Given this list of marker genes Osr1, Dvl2, Irx1, Irx3, Hoxa2, Cobl, Chrd, Meox2, Mllt3, Mafb, Irx2 (Iroquois homeobox 2), Mtf2, Msgn1, Ednra, Ripply1, Hes5, Bmp4, Dll1, Nog, Meox1 (mesenchyme homeobox 1), Six1, here is a description of the gene set: studied in species Mus musculus Mouse Gene Set: GOBP_SEGMENT_SPECIFICATION The process in which segments assume individual identities; exemplified in insects by the actions of the products of the homeotic genes.